The following is a description of a gene set: species: Mus musculus Any process that activates or increases the frequency, rate or extent of response to endoplasmic reticulum stress. Mouse Gene Set: GOBP_POSITIVE_REGULATION_OF_RESPONSE_TO_ENDOPLASMIC_RETICULUM_STRESS, and this is the list of marker genes: Pik3r1, Ptpn2, Rnf183, Tmem259, Atf6, Bak1, Rnf185, Sirt1, Xbp1, Usp13, Rnft1, Eif2a, Rnft2, Tmx1, Ern1, Agr2, Wfs1, Atxn3, Tmem33, Spop, Bax, Nck1 (NCBI Gene Id 319390), Serinc3, Herpud1, Fcgr2b, Ubqln2, Bcap31, Tmem67, Sgta, Stub1, Bok, Eif2ak3, Bag6, Cav1, App, Ubqln1, Nck2